The following is a description of a gene set: Genes involve in metabolism of bile acids and salts. Human Gene Set: HALLMARK_BILE_ACID_METABOLISM from publication Liberzon A, Birger C, Thorvaldsdóttir H, Ghandi M, Mesirov JP, Tamayo P (PMID 26771021) species: Homo sapiens, and this is the list of marker genes: EPHX2, LIPE, ABCA3, RXRA, PNPLA8, KLF1, CH25H, DHCR24, ABCA2, PEX1, SCP2, ABCA8, GSTK1, ABCA6, PEX19, NR3C2, GC, GNPAT, AGXT, SLCO1A2, IDH1, CYP8B1, ABCD2, SULT1B1, BMP6, SOAT2, ABCA1, DIO2, PEX26, CYP39A1, ABCA4, TFCP2L1, AR, ABCG4, HSD17B6, HSD3B7, RXRG, ACSL1, MLYCD, PIPOX, LCK, FADS2, APOA1, CROT, SOD1, PEX12, IDH2, EFHC1, HAO1, CYP7A1, SLC27A2, SULT2B1, ABCD1, SLC23A2, ALDH8A1, PHYH, PEX7, NR1H4, PEX6, CYP27A1, FADS1, SLC27A5, NR0B2, RBP1, RETSAT, ISOC1, ABCG8, AMACR, HACL1, LONP2, GNMT, ALDH9A1, TTR, NEDD4, ABCA5, SLC23A1, ACSL5, ALDH1A1, HSD17B4, PEX11G, BCAR3, PFKM, ATXN1, AQP9, CYP46A1, OPTN, SLC29A1, PEX16 (peroxisomal biogenesis factor 16), NPC1, PEX13, AKR1D1, NUDT12, CAT, NR1I2, BBOX1, ABCD3, DIO1, IDI1, FDXR, PRDX5, GCLM, SLC35B2, SERPINA6, PAOX, HSD3B1, PECR, PEX11A, SLC22A18, HSD17B11, CYP7B1, PXMP2, ABCA9